Given this list of marker genes SKA1, MTBP, SPDL1, INCENP, MAD1L1, PHIP, FGF8, ANAPC5, DAPK3, CDC16, LCMT1, DUSP1, BUB1, HOXA13, XRCC3 (NCBI Gene Id 7517), CD28 (CD28 molecule), L3MBTL1, ZW10, TRIP13, CUL7, PIN1, DLGAP5, ANAPC11, CUL9, IGF1, CDC42, PKMYT1, PSMG2, RAD21, BIRC5 (baculoviral IAP repeat containing 5), BUB3, APC, SH2B1, AURKA, BMP7, BORA, PDXP, NME6, ANAPC15, CDCA2, PDGFB, AURKAIP1, ATM, EREG, IGF2, BMP4, FBXW5, CDC25C, ZWINT, TTK, FBXO5, CCDC8, GEN1, PRAP1, LRP5, CDC23, MAD2L1BP, DMRT1, SPHK1, PRP4K, MAD2L2, SPC24, IK, ZWILCH, EGF, CUL3, CDC20, KIF20B, NUSAP1, ANAPC7, DYNC1LI1, FBXO43, MAD2L1, KNTC1, EDN1, RCC1, NUF2, CHEK1, BTC, EPGN, UBE2C, CDK5RAP2, NDC80, SMPD3, IL1A, OBSL1, INSR, PRMT5, CCNB1, INS (insulin), IL1B, TGFA, CENPF, KLHL22, DRD3, PLK1, ESPL1, NSMCE2, EDN3, CAV2, KNL1, TNF (NCBI Gene Id 7124), TOM1L2, SPC25, PDGFRB, HASPIN, TPR, NEK2, NFE2L1, TOM1L1, ZNF207, RB1, CDCA8, MKI67, USP44, SKA3, BUB1B, AURKB, NUP62, TEX14, here is a description of the gene set: species: Homo sapiens Any process that modulates the frequency, rate or extent of mitosis. Human Gene Set: GOBP_REGULATION_OF_MITOTIC_NUCLEAR_DIVISION